Given this list of marker genes CTU2, PITX1, CEP290, PDE6D, TCTN2, CEP120, SALL1, TFAP2A, CILK1, RPGRIP1, B9D2, EXTL3, OFD1, CDC45, NELFA, GLI1, CSPP1, TCTN1, LETM1, LMBR1, CTBP1, CPLANE1, ZNF699, RAB34, HOXD13 (NCBI Gene Id 7859), GJA1, TCTN3, MKS1, TMEM107, DACT1, ZSWIM6, INTU, IFT172, PIGG, NSD2, CEP41, COLEC10, HYLS1, TXNDC15, CENPF, SMO, TMEM216, RNU4ATAC, IFT43, CC2D2A, TMEM231, WNT7A, TMEM67, IFT57, EFTUD2, C2CD3, SALL4, FAM149B1, PUF60, TMEM237, HEATR3, IFT80, CHN1, WDR35, FGFR2, FGFRL1, B9D1, PHF8, DYNC2I2 (dynein 2 intermediate chain 2), NEK9, KIAA0753, BHLHA9, MEGF8, MAFB, DYNC2H1, RPGRIP1L, RAB23, KIF7, KIAA0586, TOPORS, HEPACAM, NEK1, PTEN, FANCD2, DYNC2I1, CNTNAP2, FLNA, GLI3, CPLX1, here is a description of the gene set: A form of polydactyly in which the extra digit or digits are localized on the side of the thumb or great toe. Preaxial polydactyly species: Homo sapiens Human Gene Set: HP_PREAXIAL_POLYDACTYLY